Given this list of marker genes HCFC1R1, ARRB2, CHMP2A, GPX1, BCAP31, NDUFS8, TRAP1, VPS28, NRGN, GPR37, ARL4A, NIPSNAP1, SNRPA, RBM10, ARPC2, ATP6AP1, DEGS1, CLTA, DPF2, GNPDA1, PMP22, NDUFA1, HAX1, NDUFS7, RNPS1, RUVBL2, ENDOG, PLAAT3, CCT7, NDUFAF3, MAL, MRPL23, B3GAT1, CACNG3, NELFE, ACTR1A, ATP6V0E2, DCXR, UQCRQ, CX3CR1, COL9A3, MAST3, NTHL1, NBL1, NUP93, ATP6V0B, TALDO1, PMM1, PAFAH1B3, ZMAT4, ECI1 (NCBI Gene Id 1632), SPAG7, DCTN2 (dynactin subunit 2), DHPS, ECSIT, GRHPR (glyoxylate and hydroxypyruvate reductase), COX7A1, RABAC1, NUDC, SAC3D1, KLHL21, PEF1, SNX6, SUMO3, COX4I1, ACTL6B, NCALD, RPS29, STOML1 (NCBI Gene Id 9399), TRAPPC12, TPI1, GDI1, CRYAB, ACOT7, AHSA1, SLC25A11, IMPDH2, ETFB, RPL13 (ribosomal protein L13), PES1, DNAJB2, STX7, AMPD2, FTO, DTX4 (deltex E3 ubiquitin ligase 4), SEC14L5, COX8A, ESYT1 (extended synaptotagmin 1), KLK6, HDGF, PAK6, TMEM147, RNH1, STARD7, TAX1BP1, COX7C, HRAS, PPIA, ATOX1, PSMB5, BBLN, FNDC4, CLASP2, AKR1A1, AKR1B1 (NCBI Gene Id 231), CTDNEP1, RAP1GAP2, VPS51, MADD, TUFM, EXOC3, EIF6, NDUFB1, CX3CL1, UQCRB, DHX30, CREB3, SF3B2, NSG2, FBXO9, ACD, CKB (NCBI Gene Id 96634), TUBA4A, LMAN2L, NDUFC1, PTGDS, PIN1, FXYD7, BMERB1, MAPK3, OS9, ATP5MC1, GABBR1, MARCKSL1, GNAZ, NDUFA7, SFXN3, CDIPT, PUF60, PARP1, SUCLG1, GTF3C1, PFDN1, RPS8, EIF3G, here is a description of the gene set: from publication Kim S, Webster MJ (PMID 18762803) Genes whose expression in brain significantly and negatively correlated with the duration of all psychiatric disorders studied. Human Gene Set: KIM_ALL_DISORDERS_DURATION_CORR_DN species: Homo sapiens Cytoarchitectural abnormalities have been described in the prefrontal cortex of subjects with schizophrenia, bipolar disorder and depression. However, little is known about the gene expression profiles associated with these abnormalities. Genome-wide expression profiling technology provides an unbiased approach to identifying candidate genes and biological processes that may be associated with complex biological traits such as cytoarchitecture. In this study, we explored expression profiles associated with the abnormalities by using publicly available microarray metadata and cytoarchitectural data from post-mortem samples of the frontal cortex from 54 subjects (schizophrenia, n=14; bipolar disorder, n=13; depression, n=12 and controls n=15). Correlation analysis between genome-wide expression levels and cytoarchitectural traits revealed that genes were significantly correlated with a decrease in the number of perineuronal oligodendrocytes across all subjects. A total of genes were significantly correlated with a decrease in density of calbindin-positive interneurons across all subjects. Multiple biological processes including cellular metabolism, central nervous system development, cell motility and programmed cell death were significantly overrepresented in both correlated gene lists. These findings may provide novel insights into the molecular mechanisms that underlie the cytoarchitectural abnormalities of perineuronal oligodendrocytes and calbindin-containing GABAergic interneurons in the prefrontal cortex of the major psychiatric disorders.